Given this list of marker genes SLC35D1, TLCD4, GFI1B, PLSCR1, SMIM7, MAT2B, CLCN3, EIF3B, EIF4E, QDPR, GCLM, GTF3A, PAWR, FADS1, PLS3 (NCBI Gene Id 5358), FHL2, CCR5, STX7, SCAMP1, LYRM2, FCER1A, TPM4, APLP2 (amyloid beta precursor like protein 2), CHIA, ACADM, COMT, UBE2D3, COX6B2, LXN, DYNLT2, IRF6, C15orf39, RXYLT1, GLB1L, S100A11, TFCP2L1, AGRN (NCBI Gene Id 389836), GAS2, ITFG1, here is a description of the gene set: We mapped quantitative trait loci that accounted for the variation in hematopoietic stem cell (HSC) numbers between young adult C57BL/6 (B6) and DBA/2 (D2) mice. In reciprocal chromosome 3 congenic mice, introgressed D2 alleles increased HSC numbers owing to enhanced proliferation and self-renewal and reduced apoptosis, whereas B6 alleles had the opposite effects. Using oligonucleotide arrays, real-time PCR and protein blots, we identified latexin (Lxn), a gene whose differential transcription and expression was associated with the allelic differences. Expression was inversely correlated with the number of HSCs; therefore, ectopic expression of Lxn using a retroviral vector decreased stem cell population size. We identified clusters of SNPs upstream of the Lxn transcriptional start site, at least two of which are associated with potential binding sites for transcription factors regulating stem cells. Thus, promoter polymorphisms between the B6 and D2 alleles may affect Lxn gene expression and consequently influence the population size of hematopoietic stem cells. Genes up-regulated in LSK cells (bone marrow) as a function of a QTL for the size of hematopoietic stem cell (HSC) population: comparison of congenic D.B. Chr 3 (DB, small HSC population) vs parental D2 strain (huge HSC population). studied in species Mus musculus from publication Liang Y, Jansen M, Aronow B, Geiger H, Van Zant G (PMID 17220891) Human Gene Set: LIANG_HEMATOPOIESIS_STEM_CELL_NUMBER_SMALL_VS_HUGE_UP